The following is a description of a gene set: Marker genes curated from the annotated cluster as represented in the Descartes Human Gene Expression During Development database. from publication Cao J, O'Day DR, Pliner HA, Kingsley PD, Deng M, Daza RM, Zager MA, Aldinger KA, Blecher-Gonen R, Zhang F, Spielmann M, Palis J, Doherty D, Steemers FJ, Glass IA, Trapnell C, Shendure J (PMID 33184181) The gene expression program underlying the specification of human cell types is of fundamental interest. The study authors generated human cell atlases of gene expression and chromatin accessibility in fetal tissues. For gene expression, the study authors applied three-level combinatorial indexing to >110 samples representing 15 organs, ultimately profiling ~4 million single cells. The study authors leveraged the literature and other atlases to identify and annotate hundreds of cell types and subtypes, both within and across tissues. Our analyses focused on organ-specific specializations of broadly distributed cell types (such as blood, endothelial, and epithelial), sites of fetal erythropoiesis (which notably included the adrenal gland), and integration with mouse developmental atlases (such as conserved specification of blood cells). These data represent a rich resource for the exploration of in vivo human gene expression in diverse tissues and cell types. species: Homo sapiens Human Gene Set: DESCARTES_FETAL_INTESTINE_SMOOTH_MUSCLE_CELLS, and this is the list of marker genes: DES, ADRB3, ACTA2, NOG, FST, OLFML2B, PPIC-AS1, PDLIM7, POPDC3, LDB3, JPH2, CHRDL2, NIPAL4, MYH11, FRMD6-AS2 (NCBI Gene Id 145438), RGS5, PSD, SERTAD4, IL17B, FBXL22, ANO1, KCNMA1, KCND3, DSTN, MYL9, ACTG2, CNN1, CHRM2, TAGLN, MYLK, LINC00578, KCNMB1, AOC3, KCNJ8, NTM, LMOD1, CARMN, WIF1, RNU7-47P (RNA, U7 small nuclear 47 pseudogene), GREM2, TACR2, FLNA, SLITRK3, KCNA1, CAPN3, ACTA2-AS1, MYOCD, OVCH2, FGF7, TNMD, TTC23-AS1